Given this list of marker genes NCF4, IQGAP1, BRK1, ABI2, NCKAP1, ARMCX3, PREX1, PIK3R1, NCKAP1L, TFRC, PGRMC2, ABR, PIK3CA, ESYT1, VAPB, VANGL1, ARHGAP1, TRIO, MCF2, CYFIP1, PIK3R3, DEPDC1B, WASF2, CDC42, NCF2, MCAM, ARHGAP17, LAMTOR1, PAK4, RAC2, DEF6, CYBB, GARRE1, EMD, RACGAP1, PLD2, TAOK3, CYBA, PIK3R2, NCF1, CDC42EP1, ARHGAP32, TMPO, VRK2, CDC42EP4, SWAP70, DOCK10, ARHGDIA, BAIAP2L1, STBD1, ITGB1, MPP7, TIAM1, LMAN1, LBR, ARHGAP21, ABI1, SLITRK5, VAV3, DIAPH3, SAMM50, PAK2, NHS, VAV1, ARHGAP26, BCR, GIT2, DSG2, DOCK2, ARHGAP35, MTX1, OPHN1, ERBIN, LEMD3, GIT1, VAV2, ARHGAP42, SYDE1, EPHA2, PAK1, DOCK1, ANKLE2, VAMP3 (NCBI Gene Id 9341), RAB7A, ARHGAP39, DOCK4, CAV1, DOCK3, here is a description of the gene set: species: Homo sapiens Reactome Pathway: RAC2 GTPase cycle This pathway catalogues RAC2 guanine nucleotide exchange factors (GEFs), GTPase activator proteins (GAPs), GDP dissociation inhibitors (GDIs) and RAC2 effectors. RAC2 is exclusively expressed in hematopoietic cells. RAC2 is a component of the phagocytic oxidase complex in neutrophils. RAC2 is required for adhesion and mobilization of hematopoietic stem cells and progenitor cells. RAC2 is also needed for adhesion, migration and degranulation of mast cells. Mutations in RAC2 have been found in a small number of patients with primary immunodeficiencies. part of: RHO GTPase cycle